Given this list of marker genes RPSA, PLP2, LAMB3, ZFP36L2 (NCBI Gene Id 96706), APOD, STK17A, ADH1C, TIMP1, EGFR, IGFBP2, TAGLN2, SOD3, LTBP4, KCNN4, EIF1 (NCBI Gene Id 1963), SOX9, ALDH3A1, IMP3, EIF3M, AHCY, YBX3, DUSP23, SLC1A5, VSNL1, RPLP1, ITGA2, BLCAP, RPS2, NPM1, THBD, CFH, KCTD1 (potassium channel tetramerization domain containing 1), AXL, RPL13, KRT17, GPC1 (NCBI Gene Id 2817), PDLIM1, IL33, DHRS3, RPLP0, EFNA5 (NCBI Gene Id 1946), TP63, MYC, DCN, SPINK5, LMO4, HCAR2, ABI3BP, ALDH7A1, ARG2, CALD1, IFI16, ISYNA1, HAS3, FBXO32 (NCBI Gene Id 114907), RPL8, NPM3, SFN, MIR205HG, JUNB, RPL15, FBLN1 (NCBI Gene Id 2192), NACA, GPR87, DLK2, IFITM1, RPL4 (ribosomal protein L4), ALDH3A2 (aldehyde dehydrogenase 3 family member A2), CTSB, RPS3A, GAS5, PDPN, TUSC1, CYP24A1, CLDN1, LDHA, EYA2, RPL32, PERP, RGS12, CD9, ANXA2, SLC38A2, S100A2, RAB34, IGFBP7, CD177, IMPDH2, RPS6 (ribosomal protein S6), CDK4, EPAS1, FHL2, PALLD, IKBIP, RPL9, OAT, RPS5, MT2A, RPS11, RPL23, RPL14, UBC, TINAGL1, RPL5, TPM2, UGCG, LGALS1, RPS4X, ARPC2, SERPINF1, RPL10A, LGALS7B, HNRNPA1, PGAM1, PER2, C1R, MARCKS, IGFBP6 (insulin like growth factor binding protein 6), LRRC8A, CLU, PKP1, GPC3, TRPV4 (NCBI Gene Id 8098), AOPEP, CCND2, HMGB3, HNRNPH1, CDH3, TMEM237, LOXL4, CH25H, TCF4, ACTG1, EIF4B, SERPINB5, EMP3, TSC22D1, RASSF10, RPL7, SPOCK3, PRNP, BASP1, SLC3A2, RPL13AP5, TNS4, RPS7, RPL13A, DKK3, G0S2, NAP1L1, IGFBP4, TGFBI, CNN2, ENO1, ETS2, SSPN, HCAR3, SNCG, SYT8, GAPDH, DST, SH3BGRL3, RPL3, RAP2B, PRMT1, RPL6, CAPNS2, SLC43A3, ITGB4, KRT15, BTF3, RPL12, NGFR, SNHG29, FAF1, AQP3, TACSTD2, LGALS7, RPS3, F3 (NCBI Gene Id 99486), KRT5, JAM3, TLE3, RPL29, NSG1, GLTP, EEF1A1, RHOC, here is a description of the gene set: Human Gene Set: TRAVAGLINI_LUNG_BASAL_CELL species: Homo sapiens from publication Travaglini KJ, Nabhan AN, Penland L, Sinha R, Gillich A, Sit RV, Chang S, Conley SD, Mori Y, Seita J, Berry GJ, Shrager JB, Metzger RJ, Kuo CS, Neff N, Weissman IL, Quake SR, Krasnow MA (PMID 33208946)